Given this list of marker genes Brap, Rpl23a, Smc2, Or13p4, Rpl27, Tbc1d16, Shtn1, Lrrc41, Tmem179, Bri3bp, Nudt7, Med23 (mediator complex subunit 23), Slc26a1, Ppwd1, Itga6, Prcc, Sat1, Srek1, Tada1, Hap1, Neu1, Polr1b (polymerase (RNA) I polypeptide B), Rpl22, Rpl11, Edc4, Gpd2, Ramp3, Rpl35, Tprn, Tnfaip2, Ppm1l, Acsl1, Rpl34, Insig1, Slc12a9, N4bp3, Rps15, Dhx35, here is a description of the gene set: The tuberous sclerosis complex (TSC) proteins TSC1 and TSC2 regulate protein translation by inhibiting the serine/threonine kinase mTORC1 (for mammalian target of rapamycin complex 1). However, how TSC1 and TSC2 control overall protein synthesis and the translation of specific mRNAs in response to different mitogenic and nutritional stimuli is largely unknown. We show here that serum withdrawal inhibits mTORC1 signaling, causes disassembly of translation initiation complexes, and causes mRNA redistribution from polysomes to subpolysomes in wild-type mouse embryo fibroblasts (MEFs). In contrast, these responses are defective in Tsc1(-/-) or Tsc2(-/-) MEFs. Microarray analysis of polysome- and subpolysome-associated mRNAs uncovered specific mRNAs that are translationally regulated by serum, 90% of which are TSC1 and TSC2 dependent. Surprisingly, the mTORC1 inhibitor, rapamycin, abolished mTORC1 activity but only affected approximately 40% of the serum-regulated mRNAs. Serum-dependent signaling through mTORC1 and polysome redistribution of global and individual mRNAs were restored upon re-expression of TSC1 and TSC2. Serum-responsive mRNAs that are sensitive to inhibition by rapamycin are highly enriched for terminal oligopyrimidine and for very short 5' and 3' untranslated regions. These data demonstrate that the TSC1/TSC2 complex regulates protein translation through mainly mTORC1-dependent mechanisms and implicates a discrete profile of deregulated mRNA translation in tuberous sclerosis pathology. Genes translationally regulated in MEF cells (embryonic fibroblasts) by rapamycin (sirolimus) but not in response to serum deprivation. Mouse Gene Set: BILANGES_RAPAMYCIN_SENSITIVE_GENES species: Mus musculus from publication Bilanges B, Argonza-Barrett R, Kolesnichenko M, Skinner C, Nair M, Chen M, Stokoe D (PMID 17562867)